Given this list of marker genes ZNF14, MAP3K1, THOC6, KRBOX4, LMTK3, SLC46A3, CTSC, GSAP, ZC3H11A, ECHDC3, CYRIA, SLBP (NCBI Gene Id 7884), GSK3B, SENCR, SMAP2, XPO6, GPBAR1, APPL2, NEU1, HNRNPUL1, IQSEC2, NBPF10, MTRFR, OR6B1, RHOBTB1, TNFAIP2, SMAP1, PYGL, CNPY3, ARHGAP9, APBA1, CUEDC2, ABL1, WNT6, CCNL1, CLCN5, RIPOR1, LRCH3, FXYD6, MTSS1, TMEM65, NUP50, ABCC5, LRRK2, SPATA6, FAM50B, ATOSA, ADAMTS18 (NCBI Gene Id 170692), RNF146 (ring finger protein 146), GVINP1, ERBIN, LPCAT1, DAPK1, HCK, NPDC1, INPP5B, KAT7, BTBD2 (BTB domain containing 2), PSAP, INPP4A, GNAI2, ADORA3, DCANP1, CHST14, PLAU, PID1, C1orf127, ZBTB39, DEF6, TNFRSF8 (NCBI Gene Id 943), ZNF397, NLN, HTR3B, TINF2 (TERF1 interacting nuclear factor 2), GARRE1, FMN1, SPEN-AS1, FAM117A, SPACA7, RNASE6, PLEC, TPP1, HOOK2, KCNMB4, PLEKHB2, SNX20, CTSA, HPSE, COLEC12, ARHGEF18, WDPCP (WD repeat containing planar cell polarity effector), IL11, CAMKK2, NLRP12, NISCH, CAMLG, TAF5, COMMD5, KSR1, NOD2, CERT1, CNOT2, NCAPD3, ANGPTL8, TESC, TRIM4, PHACTR4 (NCBI Gene Id 65979), OLFML2B, MAML3, CALM3, ZSWIM6, MAEA, ZMYM2, LYRM9, SIDT1, ZNF565, KIF18A, PIK3IP1, MPPE1, AP2A2, APOBEC3A, NHERF1, CBX1, TTTY6, NRM, UBXN1, AP1B1, CAPG, TNFAIP8, USP51 (NCBI Gene Id 373510), LINC02145, PPOX (NCBI Gene Id 7440), BASP1, FCGR2A, DAZAP2, GIMAP5, P2RX7 (NCBI Gene Id 5027), BRI3, ADI1, HOMER3, PMF1, PEX5, SRGAP3, SEPHS2, HLA-DQB1, COL12A1, ZNF581, NR2C2, RNF213, CD37, ARHGAP26, CSF2RA, RCVRN, NUDT14, MARCHF8, HBE1, MCAM, SLC6A16, GAS6, PIAS1, SLC66A2, RSRP1, ORAI2, EIF4A2, UBA52, SEMA4D, FARP1, FOLR2, HS3ST2, CFAP90, ZFAND5, PCAT4, ASIC3, KDM2A, ZFTA, CROCCP2, LSS, ZZZ3, IRF8, NXF5, DUSP3, RNF130, RPLP2, PLXND1, TIFAB, CAPZB, PLPP6, here is a description of the gene set: studied in species Homo sapiens Decoy receptor 3 (DcR3) is a member of the TNF receptor superfamily and is up-regulated in tumors that originate from a diversity of lineages. DcR3 is capable of promoting angiogenesis, inducing dendritic cell apoptosis, and modulating macrophage differentiation. Since tumor-associated macrophages (TAMs) are the major infiltrating leukocytes in most malignant tumors, we used microarray technology to investigate whether DcR3 contributes to the development of TAMs. Among the DcR3-modulated genes expressed by TAMs, those that encode proteins involved in MHC class II (MHC-II)-dependent antigen presentation were down-regulated substantially, together with the master regulator of MHC-II expression (the class II transactivator, CIITA). The ERK- and JNK-induced deacetylation of histones associated with the CIITA promoters was responsible for DcR3-mediated down-regulation of MHC-II expression. Furthermore, the expression level of DcR3 in cancer cells correlated inversely with HLA-DR levels on TAMs and with the overall survival time of pancreatic cancer patients. The role of DcR3 in the development of TAMs was further confirmed using transgenic mice over-expressing DcR3. This elucidates the molecular mechanism of impaired MHC-II-mediated antigen presentation by TAMs, and raises the possibility that subversion of TAM-induced immunosuppression via inhibition of DcR3 expression might represent a target for the design of new therapeutics. Genes up-regulated in comparison of macrophages treated with control (hIgG1) versus those treated with TNFRSF6B. from publication Chang YC, Chen TC, Lee CT, Yang CY, Wang HW, Wang CC, Hsieh SL (PMID 18349319) Human Gene Set: GSE10856_CTRL_VS_TNFRSF6B_IN_MACROPHAGE_UP